The following is a description of a gene set: Any process that stops, prevents, or reduces the frequency, rate, or extent of cell adhesion mediated by integrin. studied in species Homo sapiens Human Gene Set: GOBP_NEGATIVE_REGULATION_OF_CELL_ADHESION_MEDIATED_BY_INTEGRIN, and this is the list of marker genes: ACER2, NEXMIF, HRG, PTPN11, SWAP70 (NCBI Gene Id 23075), CYP1B1, SNAI2, JAM3 (NCBI Gene Id 84887), PDE3B, MUC1, WNK1, SERPINE1 (serpin family E member 1)